The following is a description of a gene set: species: Mus musculus Mouse Gene Set: MYO1C_TARGET_GENES from publication Yevshin I, Sharipov R, Kolmykov S, Kondrakhin Y, Kolpakov F (PMID 30445619) Genes containing one or more binding sites for (Myo1c) in their promoter regions (TSS -1000,+100 bp) as identified by GTRD version 20.06 ChIP-seq harmonization., and this is the list of marker genes: 2610005L07Rik, Gm10222, Zftraf1, Mrps11, Mrpl20, 1110038B12Rik, Tex14, Wtap, mt-Rnr1, Noc4l, Frg1, Oga, Slc25a45, Zc3h10, Yeats4, Snhg17, mt-Rnr2, Timm21, Amdhd2, Knl1, Fiz1, Trmt10b, Gm15564, Usp30 (ubiquitin specific peptidase 30), Atxn2, Fam171a1, Slc39a3, Fth1, Junb (NCBI Gene Id 16477), Ajuba, Taf13, Hspa8, Frmd8os, Neat1, Ddx19b (DEAD box helicase 19b), Zfp524, Hps1, Gcat, Commd2, Mrpl46, Gmfb, Ctcf, Gm8357, Map9, H1f3, Samhd1, Duxf1, Sfi1, Vps37c, Ddx51, Gtf3c6, Snord3a, Lamc1, Nob1, Snrnp27, Snw1, mt-Tv, Mtif2, H1f8, Tmem237, Tufm, Septin9, Gm25744, G730003C15Rik, Mir6236, Dlg1, Ddr1, Grk6